Given this list of marker genes RPS27A, MIB1, UBA52, MIB2 (NCBI Gene Id 142678), NOTCH1, JAG1, ADAM10 (ADAM metallopeptidase domain 10), DLL1, DLL4, NEURL1B, NEURL1, JAG2, ADAM17, UBB, UBC, here is a description of the gene set: studied in species Homo sapiens Human Gene Set: REACTOME_SIGNALING_BY_NOTCH1_HD_DOMAIN_MUTANTS_IN_CANCER Signaling by NOTCH1 HD Domain Mutants in Cancer